Given this list of marker genes DNAAF10, LL22NC03-63E9.3, UACA, ACAT2, LRRC1, PIK3CB, SUCNR1, NTAN1, CYC1, ATP8B1, KHDRBS2, PKD1P1, FABP5, HMGCS2 (NCBI Gene Id 3158), KLHL21, MFAP5, HEXB, FKBP6P2, VAC14, TFAP2A, FHDC1, MZT2A, ATP13A3-DT, CDKL3, DYRK2, GBE1, PDE4C, KHDRBS3, ZNF813, COMMD4, CXorf65 (NCBI Gene Id 158830), POLR2A, RAD21-AS1, DHRS9, USP22 (NCBI Gene Id 79397), ZFP62, CCDC18-AS1 (NCBI Gene Id 100131564), TNFRSF14, PDK4 (pyruvate dehydrogenase kinase 4), TSR3, ZBTB5, TNFRSF14-AS1, FAM50A (family with sequence similarity 50 member A), VAT1, ZNF208, INTS7, ST13, STMN1, IL18BP, ZBTB25, AOPEP, MYRFL, DVL2, GNPTG, ABHD14B, LINC00685, SETDB2, KAT6B, GPI, OSER1-DT (NCBI Gene Id 100507880), SLC22A3, PKD1P6, ITGB3BP, RNF13, PRICKLE1, HECTD1, NBPF1, NUMBL, NUPR1, RPS25, SNHG6 (NCBI Gene Id 641638), POLR1E, ANKRD34A, FCGR2B, ZMYM3, NACA4P, PARP6, GTF2H3, KAT14, TMC6, AP1AR, EFEMP2, LONP1, CLCN7, PMCHL1, RPS10, PLPP1, RPL14, CAPN12, FNIP2, DPPA4 (developmental pluripotency associated 4), PLCXD1, RPL38, SPAG5-AS1, EIF1B, PLD3, GOLGA8H, TUBAL3, SNAPC1, SLC26A11 (NCBI Gene Id 65011), NPC2, TMEM214, AP3S1, C7orf50, PRSS33, PAAF1, SMDT1, SMG1P5, TAF9B, UBC (ubiquitin C), MARVELD2, KLHL36, FBXW12, OXSM, CCDC15, LEP, TRAPPC2L, NPIPA1, ATP6V1E2, SBF2-AS1, BHLHE40, FUT11, CKS1B, PIK3C2B, UBXN2A, AS3MT, SLC28A3, PCDHGA4 (protocadherin gamma subfamily A, 4), GPATCH1, KRTAP4-2, SEMG1, CDK13, RPL35A, ATP2B1-AS1, STAG3L1, GAS2L3, SBNO1, DPH6, ASB10, ZSCAN30, HAUS5, EVL, POU3F2, NISCH, RPS10P5, DENND1A, ZNF395, FAM13A, RPS28, PTMA, PHC1, RPL12, SYNM, CAVIN1, DOK2, KRBA2, HSD17B4, CNNM2, CYP3A4, ESPNL, ARMCX2, ALG14, CFAP157, DENND2D, IL5RA, FCRLB, FAM161B, IGHMBP2, UBE2D2, CCR5, TLCD4, MIR9-1HG, FKBP4, M6PR, DBI, LRRC39 (leucine rich repeat containing 39), CRKL, ZNF160, BRI3, STRADB, KCNA3, TPST2, LINC00847, PPARA, DUXAP10, C12orf60, LPAL2, PLA2G7 (NCBI Gene Id 7941), SGSH, NAP1L1, here is a description of the gene set: from publication Schwartz JT, Bandyopadhyay S, Kobayashi SD, McCracken J, Whitney AR, Deleo FR, Allen LA (PMID 22986450) Human Gene Set: GSE37416_12H_VS_48H_F_TULARENSIS_LVS_NEUTROPHIL_DN studied in species Homo sapiens Genes down-regulated in comparison of control polymorphonuclear leukocytes (PMN) at 12 h versus PMN treated with F. tularensis vaccine at 48 h. We demonstrated recently that both constitutive and FAS-triggered apoptosis of human neutrophils are profoundly impaired by Francisella tularensis, but how this is achieved is largely unknown. To test the hypothesis that changes in neutrophil gene expression contribute to this phenotype, we used human oligonucleotide microarrays to identify differentially regulated genes in cells infected with F. tularensis strain LVS compared with uninfected controls. In order to examine the effect of F. tularensis on the neutrophil transcriptome, we performed microarray expression analysis on human neutrophils treated with F. tularensis subsp. holarctica live vaccine strain (LVS).